Given this list of marker genes PHKA2, IGDCC4, MMS22L, ATP1B3 (ATPase Na+/K+ transporting subunit beta 3), DOCK7, PI4K2B, CMPK2, PIM1, MMP24, SKAP2, MPO, SIRT3, KCTD14, CSRP2, MYCN, PTPRE, DHRS11 (NCBI Gene Id 79154), LITAF, PARP16, SELENBP1, PAK1, BIN1 (bridging integrator 1), ESM1, DUSP6, TMEM40, ITGA2B, FUT8 (fucosyltransferase 8), TF, CCDC34, SLC7A8, AFP, OPTC, WNT7A, NIBAN1, MACROH2A2, ZNF768, CEBPZOS, PYGL, TYROBP, MYADM, REXO2, CMTM7, CD244, CA13, CKM, ARMCX3, CREG1, CAB39L, THYN1, CCL5, FASLG, ALOX5AP, GLIPR1, SERPINB1, CNN2, CPA3, CD302, SLCO6A1, DKKL1, ITGAX, LGALS1, STBD1, VAV3, UAP1L1, NR2F6, ADD3, IRF5, MED7, OTULINL, GSTM3, SCIN (scinderin), HHEX, ZNF821, CD34, IER3, STEAP3, NEDD4 (NEDD4 E3 ubiquitin protein ligase), CABLES1, LYL1, CRYZL1, PLSCR1, P2RX4, VIM, RIPOR1, CLEC10A, MAPRE2, RIPK1, CST7, PTGER3, ATP13A2, PKIB, ATP1A1, GALR3, FADS3, TOP1MT, SRGN, GIMAP7, NRGN (neurogranin), RAB31, C1orf54, DYRK3, CAVIN1, ITGA4, FCGR2B, MAP3K6, PPIC, AQP9, KCTD11, SLC25A24, SPI1, FES, BCL11A, SETD6 (SET domain containing 6, protein lysine methyltransferase), CD151, THEMIS2, ARHGAP6, MIF4GD (NCBI Gene Id 57409), PDLIM7, SH2D3C, RGS18, IGFBP4, TLE1, BTK, TMCC2, AK2, CLEC4D, NUDT7, TTK, EGFL7, LYPD1, GCNT1, IQGAP2, COQ5 (coenzyme Q5, methyltransferase), CDH9, S100A6 (NCBI Gene Id 6277), RFLNB, FGF3 (NCBI Gene Id 2248), MASTL, FANCA, GM2A, GKAP1, PRKAG1, PCDHB13, HFE, HIP1R, MRC2, TSPAN4, DHFR, RASGRP2, NFE2, HSD17B12, COMT, GLIS2, ANXA1, FFAR2, ECI1, RAI14, TAS1R1, MGST1, DEPTOR, IL17RB, B4GALT6, BCL9L, LDAF1, FLNA, RHOB, APPL2, KIAA0930, SPNS2, PLXNB2, ANKRD27, TTPA, H1-6, TSPAN2, CD52, GTF3C6, TUBA4A, RGS1, CD44, LRRK1, TAGLN2, CTNNAL1, IL4R, TAL1, CD9, LACTB, PSMD13 (NCBI Gene Id 5719), PROCR, CYFIP1, HBEGF, CD48, LIF, OGFRL1, AUTS2, ADGRG3, NAPSA, S100A4, CKAP4, CEBPB, RNH1, here is a description of the gene set: studied in species Homo sapiens Genes up-regulated in comparison of DN2 thymocytes versus DN3 thymocytes. from publication Belyaev NN, Biró J, Athanasakis D, Fernandez-Reyes D, Potocnik AJ (PMID 22581009) Human Gene Set: GSE24142_DN2_VS_DN3_THYMOCYTE_UP Development of T-cells provides a unique opportunity to study cell-fate determination due to the accessability and the well defined stages of developmental stages. In order to understand the genetic programs underlying fetal and adult T‑cell fate specification we subjected highly purified fetal and adult T-cell progenitor populations to a genome‑wide transcriptional analysis. The aim was to identify molecular elements that govern T-cell fate specification as a whole but ultimately to isolate elements that were specific for a given population in a specific developmental window.